Given this list of marker genes SCN5A, TRPM4, GJA5, RYR2, CASQ2, SCN1B, here is a description of the gene set: studied in species Homo sapiens The process that mediates interactions between a Purkinje myocyte and its surroundings that contributes to the process of the Purkinje myocyte communicating with a ventricular cardiac muscle cell in cardiac conduction. Encompasses interactions such as signaling or attachment between one cell and another cell, between a cell and an extracellular matrix, or between a cell and any other aspect of its environment. Human Gene Set: GOBP_PURKINJE_MYOCYTE_TO_VENTRICULAR_CARDIAC_MUSCLE_CELL_COMMUNICATION